The following is a description of a gene set: Spasticity that increases in degree with time. Progressive spasticity studied in species Homo sapiens Human Gene Set: HP_PROGRESSIVE_SPASTICITY, and this is the list of marker genes: ARG1, OPA1, RPS6KA3, PLA2G6 (NCBI Gene Id 8398), SPTBN1, PLAA, GLRX5, DEGS1, SPG11, ZSWIM6, PAFAH1B1, TAF8, TBCD, PLP1, PSAP, GM2A, DARS2, ACP5, FA2H, NADK2, NKX6-2, GJC2, ARSA, CTNNB1, ATP13A2, POLG, MSL3, MECP2, GALC, SELENOI, HSPD1